The following is a description of a gene set: Mouse Gene Set: CHESLER_BRAIN_D6MIT150_QTL_CIS from publication Chesler EJ, Lu L, Shou S, Qu Y, Gu J, Wang J, Hsu HC, Mountz JD, Baldwin NE, Langston MA, Threadgill DW, Manly KF, Williams RW (PMID 15711545) Patterns of gene expression in the central nervous system are highly variable and heritable. This genetic variation among normal individuals leads to considerable structural, functional and behavioral differences. We devised a general approach to dissect genetic networks systematically across biological scale, from base pairs to behavior, using a reference population of recombinant inbred strains. We profiled gene expression using Affymetrix oligonucleotide arrays in the BXD recombinant inbred strains, for which we have extensive SNP and haplotype data. We integrated a complementary database comprising 25 years of legacy phenotypic data on these strains. Covariance among gene expression and pharmacological and behavioral traits is often highly significant, corroborates known functional relations and is often generated by common quantitative trait loci. We found that a small number of major-effect quantitative trait loci jointly modulated large sets of transcripts and classical neural phenotypes in patterns specific to each tissue. We developed new analytic and graph theoretical approaches to study shared genetic modulation of networks of traits using gene sets involved in neural synapse function as an example. We built these tools into an open web resource called WebQTL that can be used to test a broad array of hypotheses. species: Mus musculus Cis-regulatory QTLs (quantitative trait loci) found at the D6Mit150 region., and this is the list of marker genes: Rho, A2m, Itpr1, Slc6a1 (solute carrier family 6 (neurotransmitter transporter, GABA), member 1), Phc1, Apobec1